The following is a description of a gene set: species: Mus musculus Mouse Gene Set: REACTOME_DRUG_ADME Drug ADME, and this is the list of marker genes: Slc29a1 (solute carrier family 29 (nucleoside transporters), member 1), Ugt2a3, Ugt2a1, Ugt2b5, Gsta2, Pon1, Sult1e1, Ugt1a9, Sult2a2, Ugt2b36, Nme2, Impdh2, Impdh1, Gstt1, Ces2b, Ugt1a6a, Cyp3a25, Glyat, Nudt15, Gstp2, Acsm4, Ugt2a2, Rac1, Cndp2, Cyp3a41a, Ugt1a1, Cyp2d22, Slco1a4, Slc22a2, Cyp3a57, Nme1, Ugt2b38, Ugt1a5, Bsg, Acy1, Gstm2 (NCBI Gene Id 14863), Slco2b1, Slc22a7, Cyp2c66, Ugt1a2, Nat1 (N-acetyl transferase 1), Ugt1a7c, Guk1, Cyp3a11, Vav2 (NCBI Gene Id 99088), Slco1b2, Adh1, Ggt6, Slc29a2, Vav1, Sult2a1, Abcc2, Ugt3a1, Akr1c6, Itpa, Tpmt, Sult1a1, Slc22a3, Ugt2b37, Akr1c21, Ada, Ugt2b34, Slc29a3, Bche, Nat2, Acsm5, Serpina6, Ggt5, Slc28a3, Hprt1, Cyp3a44, Gsta3, Pon3, Cyp3a13, Hsd11b1, Gsta1, Cyp3a41b, Slc22a1, Akr1c20, Ugt2b1, Cyp3a16, Xdh, Slc28a2, Abcb1a, Pnp, Gmps, Ces1d, Ggt1, Alb, Ugt1a8 (UDP glucuronosyltransferase 1 family, polypeptide A8), Ugt2b35, Abcc1, Nat3, Cyp2e1, Glyatl3, Ggt7 (gamma-glutamyltransferase 7), Gstp1, Abcc3, Gsta5, Cyp3a59 (NCBI Gene Id 100044462), Cyp2c65, Slc16a1, Abcc4, Acsm2, Ugt3a2, Vav3, Pnp2, Nt5c2, Hsd11b2, Abcc5, Adk, Adal, Gsta13